The following is a description of a gene set: Dexamethasone-suppressible primary hyperaldosteronism Human Gene Set: HP_DEXAMETHASONE_SUPPRESSIBLE_PRIMARY_HYPERALDOSTERONISM A form of primary hyperaldosteronism in which the overproduction of aldosterone can be suppressed by the administration of dexamethasone. studied in species Homo sapiens, and this is the list of marker genes: CACNA1D, CLCN2, CYP11B2, KCNJ5, CYP11B1 (NCBI Gene Id 1584)